Given this list of marker genes Lrp5, Farp1, Crkl, Ptn, Dok7, Crk, Lrp4, Agrn, Rac1, Musk, Mesd, Fnta, here is a description of the gene set: studied in species Mus musculus Mouse Gene Set: GOBP_POSITIVE_REGULATION_OF_SKELETAL_MUSCLE_ACETYLCHOLINE_GATED_CHANNEL_CLUSTERING Any process that activates or increases the frequency, rate or extent of skeletal muscle acetylcholine-gated channel clustering.